The following is a description of a gene set: Transcriptional Regulation by NPAS4 species: Homo sapiens Human Gene Set: REACTOME_TRANSCRIPTIONAL_REGULATION_BY_NPAS4, and this is the list of marker genes: AGO2, MAGED1, ARNT2, MAPK1, CDK5, RBFOX3, BDNF, REST, TNRC6B, AGO4, RET, MAPK3, AGO1 (argonaute RISC component 1), IQSEC3, MOV10, MDM2, NPAS4, NAMPT, ARNT, AGO3, SRF, PLK2, SYT10, FOS, TNRC6C, INS, KCNIP3, TNRC6A, GEM, BMAL1, NR3C1, XPO1, CDK5R1, CREBBP